The following is a description of a gene set: from publication Dürig J, Bug S, Klein-Hitpass L, Boes T, Jöns T, Martin-Subero JI, Harder L, Baudis M, Dührsen U, Siebert R (PMID 17713554) Genes down-regulated in T-PLL cells (T-cell prolymphocytic leukemia) bearing the inv(14)/t(14:14) chromosomal aberration. studied in species Homo sapiens T-cell prolymphocytic leukemia (T-PLL) is a rare aggressive lymphoma derived from mature T cells, which is, in most cases, characterized by the presence of an inv(14)(q11q32)/t(14;14)(q11;q32) and a characteristic pattern of secondary chromosomal aberrations. DNA microarray technology was employed to compare the transcriptomes of eight immunomagnetically purified CD3+ normal donor-derived peripheral blood cell samples, with five highly purified inv(14)/t(14;14)-positive T-PLL blood samples. Between the two experimental groups, genes were identified as differentially expressed, including functionally important genes involved in lymphomagenesis, cell cycle regulation, apoptosis and DNA repair. Notably, the differentially expressed genes were found to be significantly enriched in genomic regions affected by recurrent chromosomal imbalances. Upregulated genes clustered on chromosome arms 6p and 8q, and downregulated genes on 6q, 8p, 10p, 11q and 18p. High-resolution copy-number determination using single nucleotide polymorphism chip technology in 12 inv(14)/t(14;14)-positive T-PLL including those analyzed for gene expression, refined chromosomal breakpoints as well as regions of imbalances. In conclusion, combined transcriptional and molecular cytogenetic profiling identified novel specific chromosomal loci and genes that are likely to be involved in disease progression and suggests a gene dosage effect as a pathogenic mechanism in T-PLL. Human Gene Set: DEURIG_T_CELL_PROLYMPHOCYTIC_LEUKEMIA_DN, and this is the list of marker genes: GCH1, MT1H, TRMT11, CEP57, F2R, TRAFD1, IL18R1, CDKN2AIP, HBS1L, CCSER2, HABP4, PRKCB, CTSW, CD8A, TRIM23, GLMN, OPTN, CD2, TUG1, TRAPPC10, OGA, MED17, TNFSF10, CST7, HLA-DPB1, KDM2A, CD84, MAN2A1, ANKRD12, TARDBP, TAF1D, EOGT, MCM9, ARHGAP25, PRDM1, GPR65 (G protein-coupled receptor 65), DLAT, CD58, CD28, ENOSF1, CEBPZ, BAZ2A, USP48, RAP1GAP2, KIF21B, FUBP1, DCLRE1C, CAPN2, MAN1A1, HLA-DPA1, EIF1AX, CD244, TRAV13-1, ENC1, ZNF14, DUSP12, REEP5, IDI1, EVI2B, TRAV8-6, PSME4, FAS, GTF2B, PCM1, KLRD1, RCBTB2, PPP1R12A, MICAL1, MSL2, PFKP, MTUS1, CALM1, IFNG, LCP2, WBP11, N4BP2L2, SGCB, THUMPD1, USP47, PPBP, LUZP1, SNHG14, ZNF292, YKT6, PTPRC, TBC1D4, ABCB1, RTN4 (reticulon 4), HOPX, TIPARP, HPGD, GZMA, ACAT1, SFXN3, TASOR, GGA2, NKG7, CCL4, ACSL3 (acyl-CoA synthetase long chain family member 3, NCBI Gene Id 55484), LEPROTL1, NR3C2, CFLAR, LPAR6, EED (embryonic ectoderm development), ACOT9, B3GNT2, CIR1, DSC1, NCOA1, STK17A, CLEC2B, NIBAN1, CHMP7, PMAIP1, CMC2, STAT4, SYTL2, DEGS1, PPWD1, GSAP, HIP1R, ZNF37BP, SRGN, ZNF394, CTLA4, CREBZF, RORA, MARF1, SRSF5, FHL1, DENND10P1, WDR37, ATG12, INTS6, BRAP, ARL6IP5, CDC42, KLRC1, DYNLT1, CRTAM, NAP1L2, PHACTR2, RNF19A (ring finger protein 19A, RBR E3 ubiquitin protein ligase), EIF4E2, NUP58, APOBEC3C, ATXN1, TCEAL2, ASCC2 (activating signal cointegrator 1 complex subunit 2), KIZ, TRAV36DV7, RECQL, PNISR, PPP3CC, TRIM22, GZMB, ZBTB43, HEG1, THOC1, SS18L2, GBP2, CTSL, IFITM1, HAT1, NDUFV2, PATZ1, DUSP5, ANKRD49, SEL1L3, PIK3R1, GFI1, RAB27A, PPP1R16B, CRYBG1, GPR137B, GIT2, PJA2, BCL2, STAT3, TOR1AIP1, ATM, TAB2, GNAI3, MT2A, WSB2, ALCAM, ZBTB38, PLPP1, ZNF731P, GNLY, KLHL2, CUL5, TPST2, AKR1C3, ANXA2, SFI1, NAP1L3, SYT11, SCML1, DAPP1, IK, EML4 (EMAP like 4), GZMK, HSF2, HNRNPH3, CD52, PTPRM, SLC25A37, YME1L1, DYRK2, HSPA14, SYNE3, MAF, CHN1, KHNYN, BIRC3, TNFRSF1B, C2orf68, IDS, CD48, MTMR9, SEC23A, CD59, UBL3, CD3D, TFIP11, THAP11, TNIK, LAIR2, MAP3K5, ST8SIA1, DHRS7, TESPA1, FCHSD2, NKTR, GZMH, LINC00667, CASP1 (caspase 1), TBK1, ADRB2, NLRP1, TRAF3IP3, TGFBR2, TRPC1, SLC25A28, ID2, IQSEC1, TRAV8-3, PAM, NPAT, BMAL1, TCAF1, FAM98A, ZCCHC2 (zinc finger CCHC-type containing 2), RDX, GNB5, CACNA2D2, TRBC2, GNG11 (NCBI Gene Id 2791), SYNE1, TBX21, MBP, BCAS2, CUL2, CXCR5, FBXO42, IL2RB, LGALS8, CNOT7, RAP2C, DNAJB6, CASP4, RABGAP1L, ZBED5, TGFBR3, IKZF3, ATG16L1, TES, PGRMC2, NFX1, NR2C1, EPS15, SNRK, CDKN2C, TRAV9-2, USP16, PRF1, TIAM1, GALNT10, CTR9, P2RY10 (NCBI Gene Id 27334), KLRF1, SERINC1, XCL1, ARID4B, MALT1, DDB2, DERL2, PDE4B, TRBC1, H3-3B, ARHGEF10, CREM, MT1X, ILRUN, KLRB1, SAP30L, FYN, CYLD, SRSF8, ENTPD4, RBM48, CD160, ICOS, ADGRG1, PLAAT4, HAUS3, TRAV13-2, SLC16A6, CCL5, TRAV21 (NCBI Gene Id 28662), TRDC, APMAP